The following is a description of a gene set: studied in species Mus musculus Genes predicted to be targets of miRBase v22 microRNA mmu_miR_883a_5p in miRDB v6.0 with MirTarget v4 prediction scores > 80 (high confidence targets). Mouse Gene Set: MIR_883A_5P from publication Chen Y, Wang X (PMID 31504780), and this is the list of marker genes: Fbxo28, Gpx5, Tmem108, Tnfsf8, Mtus1, Ccl24 (NCBI Gene Id 56221), Gnao1, Ap1ar, Asic2, Nbeal2, Bmp3, Wapl, Cct8, Usp3, Igf2bp2, Insc, Slf2, Fgf14, Prr9, Ccdc43, Depdc1b, Esr1, Ripply3, Dpagt1, Mapk1, Selenok, Mfsd4b2, Iws1, Pou2f1, Tent5c, Cdc42ep1, Bhlhe41, Cd300lg, Slc1a2, Naip2, Pphln1, Gtf2i, Ppl, Pafah1b1, Csnk2a1, Ywhab, Etnk1, Taf7l2, Tekt3, Calhm4, Onecut2 (NCBI Gene Id 328974), Ivns1abp, Idi2, Ehbp1l1, Epha7, Angptl2, Dpy19l3, Asb5, Rasal2, Gfm2 (NCBI Gene Id 78234), Negr1, Pdik1l, Snx27, Tmem245, Ephx3, Ccdc148, Gjc1, Ssxa1, Arhgef10, Ripk1, Grhl2, Sp1, Glis2, Sfxn5, Gabbr1, Vrk1, Gpr35 (G protein-coupled receptor 35), Snx30, Slc6a14, Rarg, Epha6 (NCBI Gene Id 13840), Cerk, Sprn, Nsg1, Zfp426, Osbpl6, Ptpn14, Tmem72, Col19a1, Slc22a15, Slc18a1, Stub1, Vash2, Medag, Atp2b3, Cxcr3, Tubgcp2, Frs2, Tecrl, Zswim5, Mrtfb, Mtcl2, Spink8, Ndc1, Rragb, Nek9 (NCBI Gene Id 353030), Zdhhc1, Dzank1, Amz2, Tmem14a, Polr1f (NCBI Gene Id 72166), Foxb1, Kdm5b, Cd209f, Adh5, Il17rd, Man1b1, Tmem183a, 1700006A11Rik, Traf3, Cntnap2, Rb1cc1, Mrpl41, Limk2, Foxp1, Tedc2, Bclaf3, Fam83f, Pcyt1a, Ccdc89, Irf9, Fcrl6, Gabrb3 (GABRB3, gamma-aminobutyric acid type A receptor subunit beta 3), Elk4 (NCBI Gene Id 98747), Alox12, Galnt1, Marchf6, Glce, Kif5a, Klc2, Egfr, Pcbp4, Pnpla3, Abca13, Pole4, Daam2, Ablim1, Atpaf1, Kcnb1, Ubqln1, Nr6a1, Sobp, Meis2, Tnks2 (NCBI Gene Id 74493), Chchd4, Nbas, Coq8a, Atp8a1, B4galt4, Syn3